The following is a description of a gene set: Human Gene Set: GOBP_REPLICATIVE_SENESCENCE studied in species Homo sapiens The process by which normal somatic cells reach an irreversible stage of cell cycle arrest following multiple rounds of replication; this end stage is associated with marked changes in gene expression and function. This is a natural barrier to unlimited proliferation of somatic cells, and is believed to be contolled by telomere shortening., and this is the list of marker genes: CHEK2, ATR, WNT16, CHEK1, PLA2R1, TERT, MIR21 (microRNA 21), CTC1, ERCC1, WRN, CDKN1A, TP53, CDKN2A, SERPINE1, MME, ROMO1, ATM